Given this list of marker genes ARHGAP4, CLEC6A, SVIL, ARHGAP18, PARVG, SPNS2, CARD10, TGFB1, LRG1, APOBR, ITGAL, NCF2, ATP2A3, AKR7A2, PLVAP, NADK, TEK, DGKA, ITGB7, MDP1, ALDH3B1, CAV2, ENO3 (enolase 3), PDLIM2, H1-0, SLC40A1, SRD5A3, BET1, TSPAN7, SIAE, FGF13, ANGPTL2, ADD3, RFNG, RECK, RAMP1, DHRS7, CX3CR1, PLCE1, FYCO1, SULF2, NAAA, LRRN1, PRKCD, PRKACA, RNF38, NRM, NHSL1, TMEM176B, RNF130, CEACAM21, CD3G, RASGRP4, CD300A, LCK, FHL1, RASA3, ADRB1, ADAMTS10, RAB6B, LDB2, SCP2, CAVIN2, ANTXR2, MAFB, MSX1, PLXNB2, GASK1B, WBP1, SYNE2, HSD17B4, PRRX2, NNT, COTL1, ADGRE5, PRPSAP2, UVRAG, PRKCB, ID4, ABCD1 (NCBI Gene Id 215), PPDPF, PTK7, OTULINL, NR1H3 (nuclear receptor subfamily 1 group H member 3), TNXB, UGP2, BMP2, CBX7, KCNJ10, PILRA, CLEC7A, GOLIM4, SMIM14, IDH1, SH2D3C, CYB5R1, COG6, MAPK3, TLX1, LIMCH1, VAV2, RARG, CXCR2, DHRS1, ARHGAP9, EBPL, SH3KBP1, B3GNT9, TGFBI, METTL22, CD96, TEC, PLBD1, MTMR6, SREBF2, EVI2B, HINT2, SRPK3, PLEKHO2, HADH, ERO1B, STAP1, APCDD1, CSF1R, PTPRM, PPP3CA, RUNX1T1, IRAG2, ACAA2, STAR (steroidogenic acute regulatory protein, NCBI Gene Id 6770), HLA-A, TGM1, EPB41L2, TCF21, RASD2, PIGP, ARHGAP21, EML3, SLC46A3, SSPN, DBP (D-box binding PAR bZIP transcription factor), PTPRF, ZNF521, MID2, MYO1F, FPR1, SUCNR1, PLOD2, FUCA1, LIPA, TMEM71, ITGAX, STK11IP, ITCH, CAV1, FMO5, HFE, HGSNAT, KCNAB2, MXRA8, VANGL1, CRIP2, TLE5, ASAP1, SMPD5, GDPD2, STAB2, ESYT1, EMC2, CAB39L, PAPSS1, NGFR, BVES, ANKMY2, PRCP, ACAT1, PRXL2B, GRHPR, MYADM, RUFY1, LPIN1, CYP4A22, ANKRD44, CTNND1, SMPDL3A, HIP1, TIMP2, TMEM35A, DES, USHBP1, ANTXR1, SEMA5A, TECR, TSC22D1, EVI2A, PGRMC1, MAN2B1, EXT2, ATP13A2, SDHAF4 (NCBI Gene Id 135154), here is a description of the gene set: studied in species Homo sapiens Human Gene Set: GSE19198_1H_VS_24H_IL21_TREATED_TCELL_UP from publication Kwon H, Thierry-Mieg D, Thierry-Mieg J, Kim HP, Oh J, Tunyaplin C, Carotta S, Donovan CE, Goldman ML, Tailor P, Ozato K, Levy DE, Nutt SL, Calame K, Leonard WJ (PMID 20064451) Genes up-regulated in T cells treated with IL21: 1h versus 24h. Interleukin-21 (IL-21) is a pleiotropic cytokine that induces expression of transcription factor BLIMP1 (encoded by Prdm1), which regulates plasma cell differentiation and T cell homeostasis. We identified an IL-21 response element downstream of Prdm1 that binds the transcription factors STAT3 and IRF4, which are required for optimal Prdm1 expression. Genome-wide ChIP-Seq mapping of STAT3- and IRF4-binding sites showed that most regions with IL-21-induced STAT3 binding also bound IRF4 in vivo, and furthermore, revealed that the noncanonical TTCnnnTAA GAS motif critical in Prdm1 was broadly used for STAT3 binding. Comparing genome-wide expression array data to binding sites revealed that most IL-21-regulated genes were associated with combined STAT3-IRF4 sites rather than pure STAT3 sites. Correspondingly, ChIP-Seq analysis of Irf4_/_ T cells showed greatly diminished STAT3 binding after IL-21 treatment, and Irf4_/_ mice showed impaired IL- 21-induced Tfh cell differentiation in vivo. These results reveal broad cooperative gene regulation by STAT3 and IRF4.